The following is a description of a gene set: studied in species Homo sapiens Any process that stops, prevents, or reduces the frequency, rate, or extent of B cell mediated immunity. Human Gene Set: GOBP_NEGATIVE_REGULATION_OF_B_CELL_MEDIATED_IMMUNITY, and this is the list of marker genes: CR1L, CR1, NDFIP1, FCGR2B (Fc gamma receptor IIb), CD46, C4BPA, FOXJ1, SUSD4, PARP3, FOXP3, CR2, C4BPB, PTPN6, BCL6